The following is a description of a gene set: studied in species Homo sapiens Any process that results in a change in state or activity of a cell or an organism (in terms of movement, secretion, enzyme production, gene expression, etc.) as a result of an interferon-alpha stimulus. Interferon-alpha is a type I interferon. Human Gene Set: GOBP_RESPONSE_TO_INTERFERON_ALPHA, and this is the list of marker genes: PDE12, OAS1, KLHL20, MX2, IFNAR1, TPR, FCAR, AXL, ADAR, IFITM1, GAS6, LAMP3, MYC, GATA3, IFNAR2, IFITM3, BST2, PYHIN1, RO60, EIF2AK2, IFITM2